The following is a description of a gene set: Any process that modulates the frequency, rate or extent of the assembly, arrangement of constituent parts, or disassembly of cytoskeletal structures containing both actin and myosin or paramyosin. studied in species Mus musculus Mouse Gene Set: GOBP_REGULATION_OF_ACTOMYOSIN_STRUCTURE_ORGANIZATION, and this is the list of marker genes: Tesk1, Carmil1, Asap3, Prox1, Synpo2l (NCBI Gene Id 68760), Clasp1, Myoc, Mylk3, Cdc42, Inpp5k, Tmsb15b2, Kiss1r, Ppm1f (protein phosphatase 1F (PP2C domain containing)), Hdac2, Rhoc, Edn1, Kank3, Smad4, Ppp1r9a, Ect2, Pik3r1, Met, F11r, Synpo, Wnt4, Fhod1, Tmeff2, Mef2c, Mfn2, Mkks, Tacr1, Fermt2, Rock2, Clasp2, Ttc8, Pik3r2, Ankrd23, Rac1, Epha1, S1pr1, Rgcc, Wnt11, Cav3, Abl1, Tgfb3, Apoa1, Limk1, Sh3pxd2b, Arhgap28, Lpar1, Gpr65, Dlc1, Ccdc88a, Arhgef10l, Braf, Nf2, Tacstd2, Bmp10, Cgnl1, Ptger4, Pfn1, Rapgef3, Pak1, Wasf2, Pxn, Kank4, Tpm1 (tropomyosin 1, alpha), Cd47, Tsc1, Arhgef10, Kank2, Mtor, Ppfia1, Tac1, Coro2b, Arhgap6, Tmsb15l, Prkcq, Tgfbr1, Smad3, Sorbs3, Itgb1bp1, Bag4, Frmd7, Arhgef18, S100a10 (S100 calcium binding protein A10 (calpactin)), Tjp1, Stmn1, Pdlim4, Bbs4, Phldb2, Nrp1 (NCBI Gene Id 270112), Limch1, Pak2, Serpinf2, Arap1, Actg1, Was, Arhgef15, Akap13, Ep300, Prkd1, Nox4, Evl, Rhoa, Rhpn1, Alms1, Ccn2, Sdc4, Pfn2, Ppm1e, Rhpn2, Arhgef5